The following is a description of a gene set: Genes down-regulated in comparison of untreated CD4 memory T cells from young donors versus those treated with TSST at 16 h. Human Gene Set: GSE36476_CTRL_VS_TSST_ACT_16H_MEMORY_CD4_TCELL_YOUNG_DN from publication Yu M, Li G, Lee WW, Yuan M, Cui D, Weyand CM, Goronzy JJ (PMID 22434910) species: Homo sapiens With increasing age, the ability of the immune system to protect against recurring infections or to control chronic infections erodes. The objective of the current study was to identify gene expression signatures in elderly CD4 T cell responses, and this is the list of marker genes: CYCS, CYP1B1, NME1, CISH, FILIP1L, PSEN2, CTNNA1, WDR77, CD86, CCL17, HRAS, RUVBL2, AGO2, FABP5 (fatty acid binding protein 5), TNF, IGSF3, IPO5, WDR3, CCT2, ZFYVE21, YWHAQ, TTI2 (NCBI Gene Id 80185), TIMM13, ENO1, CSNK2B, GCLM, POP1, MFSD5, TESC, MFN2, CCL20, TNIP2, ADO, PSMC4, MATN2, IL2RA (NCBI Gene Id 3559), GK, TJP2, HSPA1A, CTPS1, UCK2, SQLE, IFRD2, TUBG1, CDK2AP1, ATF6, NIP7, RBM47, CARS1, AK4, DNAJB6 (NCBI Gene Id 9186), ALAS1, TIMM10, UBL4A, LAMP3, EXOSC4, SOCS1, HILPDA (hypoxia inducible lipid droplet associated), NOP14, BET1, PAICS, HLA-DRB1, GNG5, TALDO1, BMS1, YBX3, HLA-DPA1, IDH3A, DCTPP1, CD200, YIF1A, MRPL20, STAT5A, AIMP2, TBL3, RPP40, CCL4, IL12RB2, AFG2B, IRF4, NUP62, DRP2, NQO1, SERBP1, PUS7, VCP, UBFD1, IMMT, IFNGR2, IFI30, EIF3B, ATF5, MTHFD2, NPM3, SAC3D1, RNF121, APOL6, GCNT1, DHX32 (DEAH-box helicase 32 (putative)), ZNF248, SND1, METTL13, EBI3, AGPAT5, ZWILCH, PWP1, ZBED2, NEFH, GMPPB, IPO4, SNX5, SLC31A2, CCL22, MAPK13, WDR46, HSP90AB1, PIGV, GNG4, UMPS, DPP3, SEPHS2, TNFAIP1, PRR3, GALR2, PTPRK, HPRT1, CLUH, TUBA1C (NCBI Gene Id 84790), MCUR1, IDH1, AKR1A1, MRPL35, PIR, PRDX4, TNIP3 (NCBI Gene Id 79931), TUBB6, SLCO4A1, NPL, CD83, STAM2, SCO2, TARBP2, PDCD11, LMNB2, CTLA4, LTA, BATF, EEF1E1, MSRB1, TNFRSF4, PMM2, FARSA (phenylalanyl-tRNA synthetase subunit alpha), MAP3K14, RCN1, BYSL, NDUFAF4, MSMO1, FH, IL1R1, WDR18, PEA15, ALDH2, SLC43A3, TARS1, CLN5, BATF3, CYP51A1, E2F6, DPH2, TAP1, BCL2L14, CREG1, MYOF, ATP6V0B (NCBI Gene Id 533), PFAS, RFTN1, PITRM1, DAPK1, NETO2, SRM, GARS1, CIAPIN1, CLIC2, FLII, KCNK5, TYROBP, TRAP1, IL9, TPI1, MGLL, PGAM1, TXN, STT3A, RAD51C, PPCDC, NCBP1, TWNK, ZKSCAN4, VDR, IER3